The following is a description of a gene set: studied in species Homo sapiens Human Gene Set: HP_ETHYLMALONIC_ACIDURIA The concentration of ethylmalonic acid in the urine, normalized for urine concentration, is above the upper limit of normal. Ethylmalonic aciduria, and this is the list of marker genes: COX16, ETFB, ETFDH, POLG, ETFA, HSPD1, SUCLG1, ETHE1, ACADS